The following is a description of a gene set: Human Gene Set: HP_INCREASED_CIRCULATING_GONADOTROPIN_LEVEL species: Homo sapiens Increased circulating gonadotropin level Overproduction of gonadotropins (FSH, LH) by the anterior pituitary gland., and this is the list of marker genes: POLA1, FBXO43 (F-box protein 43), CYP17A1, DIAPH2, SYCP3, KASH5, KISS1R, CYP11A1, CATIP, TP63, LHB, AR, SHOC1 (NCBI Gene Id 158401), CNBP, CYB5A, CCDC34, LHCGR (NCBI Gene Id 3973, luteinizing hormone/choriogonadotropin receptor), SPAG17, MSH4, MSH5, SPATA22 (spermatogenesis associated 22), NR0B1, VAMP7, NR5A1, SOX9, RPL10L, TEX11, RNF212, ESR1, MEIOB, ZSWIM7, MRPS22, POR, ZFPM2, LARS2, MCM8, C14orf39, NUP107, SYCP2L, POLR3H, FIGLA, BNC1, ERCC6, FSHR, FGD1, WT1, PNLDC1, SYCE1, GCNA, WWOX, FSHB, FKBP6, ESR2, KLHL10, PDHA2, TEX15, DNHD1, FMR1, SLC30A7, FOXL2, DHH, PPP2R3C, FANCM, DNAH10, PSMC3IP, DHX37, MCM9, STAG3, TERB1, HFM1 (NCBI Gene Id 374992), HSD17B4, HROB, SPIDR, TDRD9, BMP15, TAF4B, NSMCE2, BMPR1B, CT55, GDF9, CDH23, XRCC2, CBX2, CLPP, TEX14, SRY, SOHLH1, ZMYND15, NANOS1, GATA4, CFTR, MAP3K1, TERB2, MOV10L1